Given this list of marker genes PIK3CA, ESRRA, DUSP1, CALCOCO1, BCL2L11, PARK7, CARM1, URI1, SGK1, NPAS4, CASP9, POR, HSPA1A, MED1, VPS11, NKX3-1, ABHD2, NR3C2 (nuclear receptor subfamily 3 group C member 2), SH3RF1, FOXH1, GHRHR, NCOR1, VDR, SRD5A2, ESR1, TCF21, ATP1A1, DDIT4, EIF4E, PIAS2, ABCA3, PPP5C, ZMIZ1, MDK (NCBI Gene Id 4192), GKN2, NR0B1, S100B, NTRK3, SLIT2, DNAAF4, UCP3, JUNB, GOT1, PDX1, PDCD7, DDX17, IGFBP7, ALAD, PPP1R9B, SRD5A1, KDM4C, PTGDS, NEFL, JUND, COMT, PTGER2, JAK2, SFRP1, DEFA1B, RNF14, ESRRG, TGFB3, RPS6KB1, YAP1, ACSBG1, PAQR7, PRMT2, IL10, UCN, KDM1A, RBBP7 (NCBI Gene Id 5931), CRH, IDH1, KMT2D, HDAC3, PKN1, GPR83, UFM1, PHB2, BGLAP, LOX, PMEPA1, TGFB2, CLDN4, TNF, HMGCS2, ISL1, LCAT (lecithin-cholesterol acyltransferase), PGR, TSPO, CYBA, PARP1, NEDD4, CALM3, IGF1, NR1D1 (NCBI Gene Id 9572), CLOCK, PCK2, TADA3, EP300, USP8, TACR1, PGRMC2, CDK12, HSPA1B, BRCA1, UFL1, UFSP2, CSN1S1, MDM2, ZFP36L1, ACR, POU4F2, OXT, AQP1, SCNN1B, YWHAH, NR1H3, CRY1, MYOD1, FOXO3, PDE3A, ATP1A3, UCP2, CALR, DDX5 (NCBI Gene Id 1655), EPO, KLF9, ZFP36, PPARA, SPP1, HSPA8, JUN, SCNN1D, TAT, INHBA, HDAC6, SIRT1, FKBP4, UBE2L3, PTPRU, NCOA1, AVPR1A, TP63, MGARP, CCND1, CD38, RXRB, CEBPA, ZNF366, RELA, ADAM9, WBP2, UBA5, ZFP36L2, SAFB2, ESRRB, CLDN1, BCHE, METTL21C, PER1, KDM5D, SCGB1A1, FSHR, CNOT2, IL22, DEFA1, PADI2, GPER1, HDAC1 (histone deacetylase 1), SCNN1A, AANAT, PRKN, NKX2-2, DDX54, BMP6, VPS18, SRC, SERPINF1, GSTP1, LBH, GBA1, TMF1, AKR1C3, FOXA1, GHSR, KRAS, SMARCA4, CPS1, GNRH1, CCDC62, SCGB2A2, MT-ND3, DAB2, PAGR1, PTPRC, MAP2K1, SHQ1, LMO3, CST11, TRERF1, LATS1, CAV1, PRKCA, TRIM68, BCL2, FLT3, AIFM1, CDO1, GHR, SOX30, HMGA2, CYP7B1, TCF7L2, SKP2, ATP1A2, DDRGK1, SRARP, CREBRF, AXIN2, FOS, RXRG, RBFOX2, STC1, FOSB, ATP5F1A (ATP synthase F1 subunit alpha), NCOA2, EGLN2 (egl-9 family hypoxia inducible factor 2), TFPI, HCN2, TRIM63 (NCBI Gene Id 84676), HEYL, AR, DAXX, TFAP4, BMAL1, RWDD1, WNT7B, ZDHHC7, PAQR8, ADIPOQ, PPARGC1B (PPARG coactivator 1 beta), ASS1, ABCB1, NCOR2, ZNF764, CAD, FKRP, FAM107A, STRN3, HNRNPU, UBE3A, OR51E2, TAF7, KDM3A, HMGB2, SSTR5, CPN1, RHOXF1, SSTR4, PCNA, TAF1, ADTRP, BMI1, ALPL, NPC1, ESR2, IGFBP2, RHOA, FBXO32, REST, DSG2, AREG, GPI, GSK3A, COL1A1 (NCBI Gene Id 4970), KANK2, ANXA1, SLIT3, SSTR2, SREBF1, CRY2, DSG1, PLPP1, VPS54, RAN, STK39, SCNN1G, PPARD, SST, GABRB1, CNOT9, ACOD1 (aconitate decarboxylase 1), UCN3, FECH, PHB1, CASP3, NCOA4, FOSL2, SAFB, MSTN, NR2E1, NR2C1, FOXP1, CARD9, IL6, IL1RN, RXRA, ABCA2, RNF6, CFLAR, CBX3, CYBB, PAK1, DEFA3, NR4A3, TBX2, HSD11B2, CNOT1, NR2E3, TXNIP, NODAL, SLC12A3, PCK1, CALCR, HDAC2, ETNPPL, THBS1, AGL, UBR5, USP26, SCGB2A1 (secretoglobin family 2A member 1), ZBTB7A, NR3C1, GLB1, HMGB1, TRIP4, ERRFI1, TGFB1, EDN1, SMYD3 (NCBI Gene Id 81838), SOX10, here is a description of the gene set: Human Gene Set: GOBP_RESPONSE_TO_STEROID_HORMONE Any process that results in a change in state or activity of a cell or an organism (in terms of movement, secretion, enzyme production, gene expression, etc.) as a result of a steroid hormone stimulus. studied in species Homo sapiens